The following is a description of a gene set: Human Gene Set: GOBP_MULTICELLULAR_ORGANISMAL_MOVEMENT Any physiological process involved in changing the position of a multicellular organism or an anatomical part of a multicellular organism. species: Homo sapiens, and this is the list of marker genes: C12orf57, TNNT3, SELENON, GIGYF2, KBTBD13 (NCBI Gene Id 651356), TCAP, TNNC1, NPPC, MYH3, SLC8A3, CHRNB1, EEF2, GSTO1 (glutathione S-transferase omega 1), PRKD1, COMP, VPS35, ASCL1, TNF, CLN8, CASQ1 (calsequestrin 1), JSRP1, GSTM2, MTOR, DRD3, ITPR1, HIPK2, PVALEF, MAP1A, CCDC78, SCN4A, TNNT1, STRIT1, VPS54, VTI1A, TNNC2, STAC, RCSD1, REM1, MYH14, STAC2, TNNI1, COL6A1, MYH8, DMPK, HSP90AA1, MYH7 (myosin heavy chain 7), TNNI2, KCNJ2, ACTN3, CHRNA1, CHUK, TNNI3, TTN (NCBI Gene Id 7847), STAC3, CHRND, ADGRD1, HOMER1, GAA, DMD, CAV3, FKBP1A, DDIT3, ATP8A2, SYNM (synemin), ATP2A1